The following is a description of a gene set: Human Gene Set: GOBP_AUTOPHAGOSOME_LYSOSOME_FUSION The process in which autophagosomes, double-membraned vesicles containing cytoplasmic material, fuse with a vacuole (yeast) or lysosome (e.g. mammals and insects). In the case of yeast, inner membrane-bounded structures (autophagic bodies) appear in the vacuole. Fusion provides an acidic environment and digestive function to the interior of the autophagosome. species: Homo sapiens, and this is the list of marker genes: RAB39A, ATP13A2, DIAPH3 (diaphanous related formin 3), PIP4K2A, ZNRF2, VPS39, ZNRF1, C9orf72, PIP4K2B, RUBCNL, PLEKHM1, STX17, ARL8B, CLN3, RAB2A, TOM1